The following is a description of a gene set: Human Gene Set: GSE17721_LPS_VS_PAM3CSK4_2H_BMDC_UP Genes up-regulated in comparison of dendritic cells (DC) stimulated with LPS (TLR4 agonist) at 2 h versus DC cells stimulated with Pam3Csk4 (TLR1/2 agonist) at 2 h. mouse primary BMDCs were stimulated with tlr ligands and gene expression changes were profiled on Affymetrix arrays studied in species Homo sapiens from publication Amit I, Garber M, Chevrier N, Leite AP, Donner Y, Eisenhaure T, Guttman M, Grenier JK, Li W, Zuk O, Schubert LA, Birditt B, Shay T, Goren A, Zhang X, Smith Z, Deering R, McDonald RC, Cabili M, Bernstein BE, Rinn JL, Meissner A, Root DE, Hacohen N, Regev A (PMID 19729616), and this is the list of marker genes: PLEK, FAAP20, GPR85 (G protein-coupled receptor 85), TSTD1, GUCY1A1, CCL13, STX12, PADI4, APBB1, AHCTF1, MOS, DACH2, EDN1, EPM2AIP1, AP4B1, HSF2, SLC27A1, MTMR2, EMP1, SLC37A1, ADPGK, RPIA, SLC25A37, NEURL4, SIRT1, SLC4A8, BICD1, CSF2, EPS15L1, KLF6, LIF, TMEM267, TNF, SCGB3A1, ANKRD33B, HEMGN, RGS2, CEP55, ARID5B, NABP1, VAV3, PTCH1, ABHD10, HILPDA, RSBN1, SPRY1, NFATC2IP (NCBI Gene Id 84901), LARP1, ARSA, HDAC2, UPK3A, ATAD1, ADM, CXCR3, PELI1, KDM7A, SLC25A22, CCRL2, HBEGF, ADAM9, CSF3, NOCT, C3orf38, SELE, CD80, ISG15, TINF2, ARL4A, APOC3, SH3BGRL2, RXFP2, BDKRB2, DCK, NXF1, SEMA6C, NLRP3, NIN (ninein), IL6ST, CST7, TMEM101, PDGFC, USP47, CYP39A1, PTGER2 (prostaglandin E receptor 2), PAX7, KCTD12 (NCBI Gene Id 80710), ARHGAP21, ARHGEF3, ARHGAP31, BARHL1, IL1A, SMIM7, TMT1B, REPIN1, EGLN3, ENO2, GJA1, NUPR1, PEAK1, EVI2A, CCL7, KBTBD2, TCTN3, KCNA3, ALDH7A1, PRXL2C, HK2, DUSP1, LDLR, CRLF3, RND3, RAB21, SAP30, PAK1, GSPT1, PTPN18, CD274, BATF2, IFIH1, AFTPH, POLR3A, UBE2F, CARD19, RNF2 (NCBI Gene Id 6045), CLDND1, SUGP2, NFIL3, PLP1, CATSPERG, LRP2 (LDL receptor related protein 2), JUN (Jun proto-oncogene, AP-1 transcription factor subunit), TSC1, RSPO1, ASF1A, TJP1, TREX1, CCL4, PLAU, TSPAN15, GYPC, LCP2, IL6, ADAM12, DDX60, REXO4, PALS1, TM2D2, CNTNAP4 (contactin associated protein family member 4), ACYP1, ETS2, FOS, SYNGR4, ZFP36, TTC39C (tetratricopeptide repeat domain 39C), ARHGAP17, PRL, CHPT1, SECISBP2L, P2RY12, FAM43A, INTS12 (integrator complex subunit 12), MAP3K3 (mitogen-activated protein kinase kinase kinase 3), BAK1, RTTN, KRT86, MYLIP, SDC4, PNP, PACRGL (parkin coregulated like), TEX2, TOP2A, SMAD1, TSLP, BRCA1, TUFT1, NEDD4L, AP3M2, KIF16B, PTPRCAP, RGS1, SERPINB2, MRPL3 (NCBI Gene Id 11222), DAXX, CCL2, PPL, RAB9A, DECR2, BRCC3, MX1, TENT2, MANSC1, MOGAT2, PRPF40A, DRAM2, GPR37, UBE3A, SCG2, SMARCC1 (SWI/SNF related, matrix associated, actin dependent regulator of chromatin subfamily c member 1), IFIT3, BUB1B